The following is a description of a gene set: Genes changed in prostate cancer: androgen independent vs androgen dependent samples. The androgen-signaling pathway plays an important role in the development and hormonal progression of prostate cancer to the castrate-resistant stage (also called androgen-independent or hormone refractory). The Wnt pathway and beta-catenin contribute to prostate biology and pathology. Here application of Affymetrix GeneChip analysis revealed the genomic similarity of the LNCaP hollow fiber model to clinical samples and identified genes with differential expression during hormonal progression. The fiber model samples clustered according to the expression profile of androgen-regulated genes to provide genomic evidence for the reactivation of the AR signaling pathway in castrate-resistant prostate cancer. Pathway-based characterization of gene expression identified activation of the Wnt pathway. Together with the increased expression of AR and beta-catenin, there was increased nuclear colocalization and interaction of endogenous AR and beta-catenin in castrate-resistant prostate cancer from castrated mice. Surprisingly, no interaction or colocalization of AR and beta-catenin could be detected in xenografts from noncastrated mice. These studies provide the first in vivo evidence to support aberrant activation of the AR through the Wnt/beta-catenin signaling pathway during progression of prostate cancer to the terminal castrate-resistant stage. species: Homo sapiens Human Gene Set: WANG_PROSTATE_CANCER_ANDROGEN_INDEPENDENT from publication Wang G, Wang J, Sadar MD (PMID 19047173), and this is the list of marker genes: FN1, DST, TBC1D31, ZNF84, SGSH, CYREN, DBP, RAB27A, RABGAP1L, ZNF731P, UGT8, DCXR, PARP2, RPS14, PECAM1 (NCBI Gene Id 5175), RNF41, CDH11, NMT2 (N-myristoyltransferase 2), BAIAP2, RPLP2, CEP170B, REPS2, GADD45G, LILRB3, TNNI3K (TNNI3 interacting kinase), KAT8, MCL1, TRIM33, BDKRB1, GSTT1, MT1H, PRPF19, CDC14B, FBXO11, TOMM7, FRAT2, DZIP1, AP2A2, NR4A3, BTG2, ENTREP1, TRAPPC13, SPCS3, ID2, FAAP100, RPL39L, COL15A1, SDC2, TOP3A, RPL13, PRKAR2B, ALDH4A1, PPP1R12A (NCBI Gene Id 4659), LTB4R, DBI, SLC4A1AP, EDA, EIF3B, HGD, ARHGEF28 (NCBI Gene Id 64283), JUND, CIAPIN1, FMO1, USPL1, HDDC2, SOD2